The following is a description of a gene set: Hematopoiesis is the cumulative result of intricately regulated signaling pathways that are mediated by cytokines and their receptors. Proper culmination of these diverse pathways forms the basis for an orderly generation of different cell types. Recent studies conducted over the past 10-15 years have revealed that hematopoietic cytokine receptor signaling is largely mediated by a family of tyrosine kinases termed Janus kinases (JAKs) and their downstream transcription factors termed STATs (signal transducers and activators of transcription). Aberration in these pathways, such as that caused by the recently identified JAK2V617F mutation, is an underlying cause for diseases such as leukemias and other myeloproliferative disorders. This recent discovery, when coupled with the fact that STATs are activated by oncoproteins such as BCR-ABL, underscores the importance of the JAK-STAT pathway in both normal cellular development and disease states. STAT5 targets in hematopoietic signaling. studied in species Mus musculus from publication Baker SJ, Rane SG, Reddy EP (PMID 17934481) Mouse Gene Set: BAKER_HEMATOPOESIS_STAT5_TARGETS, and this is the list of marker genes: Ccnd2, Ccne1, Myc, Ccnd3, Ccnd1, Pim1, Bcl2